The following is a description of a gene set: studied in species Mus musculus Mouse Gene Set: GOMF_CADMIUM_ION_BINDING Binding to a cadmium ion (Cd)., and this is the list of marker genes: Prm2, P2rx2, Mt3, Mt2, Slc11a2, Nos1